The following is a description of a gene set: Human Gene Set: MODULE_16 Genes in the cancer module 15. species: Homo sapiens, and this is the list of marker genes: CDC20, IGHG3, PTPRU, UNG, MCM2, DOCK2, ACKR2, SLC5A2, GLRX, PLK1, SNRPA1, POLA2, CRHR2, FZR1, PLAU, PRB4, NEURL1, MYBL2, GADD45A, PPP5C, TBCD, SLC2A3, SBNO2, RAB31, RPS26, FGR, DDX19A, SLC43A1, NOLC1, TYMS, ADNP, IFRD2, CCL4, SIM2, JARID2, GLA, CCL7, MSMO1, TPX2, ME2, POLD2, SMPDL3B, COX7B, LDLR, LMNB2, LILRA2 (leukocyte immunoglobulin like receptor A2), AANAT, PRKDC, TRAPPC6A, LSM1, ATOSB, VSIG4, ESRRA, PTPRCAP (NCBI Gene Id 5790), CSNK2A1, SDC1 (syndecan 1), RRP1B, MRPL3, CPD, TBX1, VENTX (NCBI Gene Id 27287), BOP1, TCIRG1, GJB5, KLHL18, S1PR4, PTK2B, INPP5D, TRIP13, DVL1, BLMH, ENTREP1, P4HA1, RBBP8, ILF3, DAPK2, CHAF1A, PLEK, PRAME, DPH2, PLK3, ENG, OXCT1, CENPA, CFD, PRELID3A, RGS10, TK1, ZMPSTE24 (zinc metallopeptidase STE24), CLDN9, IKBKG, PRKCD (protein kinase C delta), AQP5, PTPN7, RRP7A, KRT86, SLA, RAB8A, TFRC (NCBI Gene Id 7037), H4C3, MMP15, ADD2, RAC2, CRYBA4, CAPG, PSD4, ZMIZ1, PRG2, CYBB, NHP2, FEN1, PKMYT1 (protein kinase, membrane associated tyrosine/threonine 1), MCM6, ARHGEF2, EPB41L3, NPC1, AHSG, FEV, HSD17B10 (NCBI Gene Id 50828), EDC4, AMELX, CTSG, MNDA, TGFB1, CXCL8, FADS2, ITGA2B, ST3GAL4, ITSN1, GMPS, IFT25, BCKDHA, IMPA2, TRIM16, AGPAT2, COPS3, CCL2, LAIR1, CTNNBIP1, COMP, CCND2, DUSP6, BMP10, SERPINB2, TTLL12, GPA33, PTP4A3, ATP1B2, AURKB, MMP9, TOMM40, ATP11A, TMEM106C, IRAK1, PLCG2, ITGA6, NTSR2, CSTA, GRAMD4, DDX21, SLPI, TNFRSF10B (NCBI Gene Id 8795), MPO, MLC1, HTR7, PMM2, ECE2, SMS, CFP, COL2A1, ITGA10, SLC1A5, TNXB, ODF1, BDH1, VAMP7, TFDP1, NFKBIB, DOLK, MAP2K3, ST6GALNAC4, NR1D1, ADRA1D, VDAC2, PSMA4 (NCBI Gene Id 5685), GTF2H3, LSP1, LCP2, WAS, ZPR1, RNASE2, RIBC2, S100A8, H2BC12, ZYX, PHF10, METAP1, SHMT2, MSH6, TARBP2, LSM3, LMO2, GNA15, SPN, LIF, AVPR1B, DARS1, TNFRSF1B (TNF receptor superfamily member 1B), WIZ, CDK2, C8B (complement C8 beta chain), PKN1, ZWINT, IER3, RAC3, SHBG, TUB, DKK4, LST1, CYP4B1, PAX9, KIF11, BRD4, ORM2, ZIC2, COPS2, ARID1A, TMX1, PIGC, HSPB2, CYP4F12, EPAS1, TNFAIP8 (TNF alpha induced protein 8), LBP, PAICS, PIGB (NCBI Gene Id 9488), LPAR2, MAD2L1, ATF5, RPA1, ARID3A, FCER1G, GMPR, RAP1A, QSOX1, TNFRSF25, ESPL1, CYP2C18, VBP1, FDFT1, HSF4, FADS1, GPSM3, APEX1, OAS2, RAD54L, SRSF2, ANPEP, MYCBP, HCLS1, PROC, FAM107A, ITGB2, AQP8 (NCBI Gene Id 343), LRCH4 (leucine rich repeats and calponin homology domain containing 4), STMN1, RPA3, PFKFB2, NCF4, MSX1, PTP4A1, DTX4, LGALS9 (NCBI Gene Id 90793), CCNF, MAPKAPK3, KDM5C, CTSC, MYL2, TDG, HAP1, CD33, TCF12, SLBP, LLGL2, ARPC4, LAPTM5, CES1, GALR3, AK2, PAX7, DCAF7, PYGL, EEF1E1, RASSF2, BUB1B, SLC5A6, SORD, SLC6A6, GPR3, SRGN, SERPINB1, SLC2A1, LRP3, GTSE1, FLT3, KIAA0513, DDX39A, ACTN1, ACD, PPP3CC, ARTN, PTTG1, ANXA1, TCF7, CCL3, CCT6A, LCP1, UBE2C, CCHCR1, SNX1, S100P, RRM1, SNRPB2, CD47, WEE1, CD22, SYNCRIP, TMSB4Y, NECTIN1, NMI, HTR3A, SFTPC, SLC16A3, ADAM10, SERBP1, NUDT1, CCNE1, NMB, SRRM2, KRT31, PTPRC, ARHGDIB, CRYAA, FUT7, PLIN2, PRTN3, ICAM3, SLC7A5, ARHGEF6, RHOG, CNKSR1, NPM3, GYG1, RREB1, HRG, TMEM97, CELF2, NUP50, TAF1, CD8B, SEMA3F, PCLAF, POU4F1, MCM5, GSPT1, EIF2S3, CARD10, SLC6A7, CDA, EFNA2, CCND3, FAM53B, ALAS2, MME, CDC42EP1, S100A11, KIF21B, PLAUR, ZBED4, BASP1, CXCR4, FDXR (NCBI Gene Id 2232), ARC, MYC, RAB5C (RAB5C, member RAS oncogene family), MSH2, CDV3, CLCNKA, IL2RG, TNF, IFNGR1, M6PR, SULT4A1, AIMP2, SSR1, LPXN, HCK, BMP1, EIF4EBP1, SEMA6C, AIF1, KYNU, ADSL, ASNS, NDC80, STX10, S100A4, NCBP2, HPRT1, EXOSC2, TOP2A, PNP, MYB (MYB proto-oncogene, transcription factor), PIGR, DDX11 (NCBI Gene Id 93260), PCNA, SCN4A, S100A9, CORO1A (coronin 1A), DNMT1, MAGI1, DOK1, HMMR, GNAQ, CALU, PRPF19, NUP205 (nucleoporin 205), NRG2, MRPL12, PRRC1, HK3, CYP1B1, UGT2B15, SLC7A11, CD53 (CD53 molecule), SEC22B, IRF5, ARSL (arylsulfatase L), H2AX, ELAVL2, CCNA2, TFDP2, CDKN2C, LRIT1, ARHGAP4, GPR161, CST7, IGF2, CITED2, RCC1, IFIT1, ALOX5AP, HTR4, FOXM1, PDGFRA, GGH, GYPB, CDK5R1, SLC25A1, OGG1, CHST1, HAT1, PLEKHB1, SLC39A6, ARHGDIG, KCNQ3, KRT4, INSIG1, SH3BP1, LGR5, CKS2, NUP62, LSM4 (LSM4 homolog, U6 small nuclear RNA and mRNA degradation associated), CAD, GAGE12F, AP1M1, CASP2, HMGN4 (high mobility group nucleosomal binding domain 4), EMP3, ORC1, GPR183, FHIT, LMNB1 (lamin B1), F7, SLC6A11, ATP4A, KCNJ4, RPS6KA1, PSMG1, RRP9, UBE2E1, CSTF3, CCL5, FLNA, TYR, KCNAB1, SNRPC, RNPEP, CORT, SOX10 (SRY-box transcription factor 10), ACR, ADAM19, MAN2B1, ZNF117, LAMP2, PXN, KCND3, SCN2B, CREG1